Given this list of marker genes Ece2, Calm3, Emc9, Gabrq, Sgpp2, Klk6, Cabp7, Eif5a2, Chrnb4, Vwa5b2, Lgals8, Glra4, Baiap3, Nrg1, Ndufb5, Dlk1, Marchf2, Sv2c, Cat, Gpr101, P2rx6, Ublcp1, Rassf4, Hmga1, Kank4, Mtap (NCBI Gene Id 66902), Tsc22d3 (NCBI Gene Id 14605), Tns1, Ypel5, Entpd3, Dnpep, Adamts2, Ankrd35, Endod1, Steap2, Cct8, Kcnj14, Rtn2, Rnd2, Hspb8, Ankrd55, Ahnak2, B3galt5, Pcsk1n, Ebf3, Gpc5, B630019K06Rik, Maged2, Vdac2, Zim1 (zinc finger, imprinted 1), Get1, Clgn, Panx2, Cdh23, Esrrg, Gfap, Tmem176a, Spp1, S100b, Fam13a (NCBI Gene Id 58909), Cd59a, Glra1, Crot, Cyp27a1, Coprs, Akap12, Dpysl3 (dihydropyrimidinase-like 3), Vcf2, Htr2c, Phospho1, Abhd4, Kcng4, Glra2, Ltbp3, Rab37, Hcn2, Kif5b, Ndufs1, Abhd3 (NCBI Gene Id 106861), Coq7, P2rx5, Slc18a2, Impa2, Hcrtr1, Kcnab2, Capn1, Anxa5, Fstl1, Pmp22, Slc17a6, Mrap2, Tmem205, Slc6a5, Cd83, here is a description of the gene set: Mouse Gene Set: LEIN_PONS_MARKERS Molecular approaches to understanding the functional circuitry of the nervous system promise new insights into the relationship between genes, brain and behaviour. The cellular diversity of the brain necessitates a cellular resolution approach towards understanding the functional genomics of the nervous system. We describe here an anatomically comprehensive digital atlas containing the expression patterns of approximately genes in the adult mouse brain. Data were generated using automated high-throughput procedures for in situ hybridization and data acquisition, and are publicly accessible online. Newly developed image-based informatics tools allow global genome-scale structural analysis and cross-correlation, as well as identification of regionally enriched genes. Unbiased fine-resolution analysis has identified highly specific cellular markers as well as extensive evidence of cellular heterogeneity not evident in classical neuroanatomical atlases. This highly standardized atlas provides an open, primary data resource for a wide variety of further studies concerning brain organization and function. from publication Lein ES, Hawrylycz MJ, Ao N, Ayres M, Bensinger A, Bernard A, Boe AF, Boguski MS, Brockway KS, Byrnes EJ, Chen L, Chen L, Chen TM, Chin MC, Chong J, Crook BE, Czaplinska A, Dang CN, Datta S, Dee NR, Desaki AL, Desta T, Diep E, Dolbeare TA, Donelan MJ, Dong HW, Dougherty JG, Duncan BJ, Ebbert AJ, Eichele G, Estin LK, Faber C, Facer BA, Fields R, Fischer SR, Fliss TP, Frensley C, Gates SN, Glattfelder KJ, Halverson KR, Hart MR, Hohmann JG, Howell MP, Jeung DP, Johnson RA, Karr PT, Kawal R, Kidney JM, Knapik RH, Kuan CL, Lake JH, Laramee AR, Larsen KD, Lau C, Lemon TA, Liang AJ, Liu Y, Luong LT, Michaels J, Morgan JJ, Morgan RJ, Mortrud MT, Mosqueda NF, Ng LL, Ng R, Orta GJ, Overly CC, Pak TH, Parry SE, Pathak SD, Pearson OC, Puchalski RB, Riley ZL, Rockett HR, Rowland SA, Royall JJ, Ruiz MJ, Sarno NR, Schaffnit K, Shapovalova NV, Sivisay T, Slaughterbeck CR, Smith SC, Smith KA, Smith BI, Sodt AJ, Stewart NN, Stumpf KR, Sunkin SM, Sutram M, Tam A, Teemer CD, Thaller C, Thompson CL, Varnam LR, Visel A, Whitlock RM, Wohnoutka PE, Wolkey CK, Wong VY, Wood M, Yaylaoglu MB, Young RC, Youngstrom BL, Yuan XF, Zhang B, Zwingman TA, Jones AR (PMID 17151600) Top 100 ranked genes most specific to pons region (P) of the adult mouse brain. studied in species Mus musculus